The following is a description of a gene set: A small/hypoplastic or absent/aplastic 3rd (middle) finger. Aplasia/Hypoplasia of the 3rd finger Human Gene Set: HP_APLASIA_HYPOPLASIA_OF_THE_3RD_FINGER species: Homo sapiens, and this is the list of marker genes: GNAS, NSDHL, GDF5, EN1, COL2A1, TBX5, TBX3